Given this list of marker genes Cdip1, Mex3c, Trir, Tm9sf3, Trim47, Mnt, Grm5, 6430571L13Rik, Dll4, Mettl23, Tmem164 (NCBI Gene Id 209497), 1110032F04Rik, Dmrtc2, Fzd4, Nxf1, Armc10 (NCBI Gene Id 67211), Dock9, Suco, Nacc2, Prkab1, Nedd8, Med22, H2bc6, Prkcg, Shisa6, Angpt2, 9930111J21Rik1, Poln, Tbc1d13, Pald1, Fbxo3, Grk6, Sgk1, Cd200r3, Zfp395, Fbn1, Chtf8, Ceacam1, Acad10, Cgnl1, Fam91a1, Ganab (NCBI Gene Id 14376), Sntg2, Cables1, Wdr44, Inpp4a, Rtf2, Trpa1, Ctsll3, Dchs1, Col6a3, Il31ra, Emp2, Ctdnep1, Tc2n, Acox1, Cpn1, Nsd2, Entrep2, Mapt, Gpatch8, Mbtd1, Naa15, Plg, Pik3c2b, Rxra, Popdc3, here is a description of the gene set: from publication Chen Y, Wang X (PMID 31504780) studied in species Mus musculus Mouse Gene Set: MIR_1955_5P Genes predicted to be targets of miRBase v22 microRNA mmu_miR_1955_5p in miRDB v6.0 with MirTarget v4 prediction scores > 80 (high confidence targets).